The following is a description of a gene set: species: Homo sapiens Pheochromocytoma Human Gene Set: HP_PHEOCHROMOCYTOMA Pheochromocytomas (also known as chromaffin tumors) produce, store, and secrete catecholamines. Pheochromocytomas usually originate from the adrenal medulla but may also develop from chromaffin cells in or about sympathetic ganglia. A common symptom of pheochromocytoma is hypertension owing to release of catecholamines., and this is the list of marker genes: MAX, CDKN1A, DLST, IFNG, PRKAR1A, RET, CCND1, SDHC, DNMT3A, SDHA, VHL, TSC1, MEN1, EPAS1, HRAS, SDHAF2, TSC2, TMEM127, CDKN1B, FH, MDH2, CDKN2C, SDHB (NCBI Gene Id 96200), CDKN2B, SDHD, SLC25A11, NF1, KIF1B